Given this list of marker genes GM2A, DYNLT2B, WDPCP, GLUD1, TJP2, ZNF157, DENND3, SEL1L3, SPEN, XRN2, ZFYVE27, CLN3 (CLN3 lysosomal/endosomal transmembrane protein, battenin), SLC25A35, ELAC1, ARHGAP26, SLC15A4, P3H3, TERF2, RAB38, RPL38, RINT1, MACO1, BCO2 (beta-carotene oxygenase 2), EML6, ADAM22, TMEM191C, SRPK2, CCR6, SNAPC2, TMEM241, RCAN3, MAP3K2, DBF4, MAN2B1, RAMP1, CD4, BUB3, DUSP7, TMEM176B, PLEKHG3, SLC23A3, CD300C, CDK2AP1, HOXA7, THNSL1, ARL2BP, KMT2D, CDKL3, SLA, TMEM273, ZCCHC24 (zinc finger CCHC-type containing 24), ACSM3, AFMID, MCCC2, CD300LB, URI1, CD68, KRT16, KAZN (kazrin, periplakin interacting protein), CCNY, ACSS1, SGSH, GSN, MMGT1, ALKBH8, ZNF623, TSPAN9, DNAJB14, SLC9A9, CD74, FERMT3, CCDC28A, CYB5R1, SLC43A2, CEP162, CLEC4G, ZNF418, DCLRE1C, ACAD9, ALOX15, CSAD, BCKDHB, COL17A1, RASGRP3, CNR2, RUNDC1, AKAP11, AMPD3, CIPC, GBA1, NFATC1, KLRC2, TCTA, SHLD1, SLC29A3, PITHD1, HAGH, SETX, CARM1, TFAP4, HELB, NBDY, ILK, IFNGR1, APOE, FAM161A, DCP1B, IGLC7, FMNL3, TMEM175, RAC2, NAV1, CMYA5, ARHGAP9, C6orf136, VHL, PHF7, SZT2, TTC7A, MTCP1, DGKD, ESAM, FIBP, MSRB2, SERPINA1, SLC25A45, AP1M1, ABI3, PACS1, FAM13B, CYP7A1, NFYC, DHCR24, RAPH1, ZNF653, CARD10, FICD, TET2, SUPT5H (SPT5 homolog, DSIF elongation factor subunit), FLYWCH1, LIPA, LPXN, L1CAM, LINC00511, CSNK1E, SDCCAG8, PATJ, ZNF445, MYCBP2, B4GALT6, WDR3, INPP5K, UTRN (NCBI Gene Id 7402), CARD6, CD300LG, PDLIM2, FAM89B, TDO2, RACK1, POGLUT2, RTN1, SESN3, RAD23A, ACO1, BICRA, PLP2, RIPOR2, BTBD2, HLCS, MAPK7, STARD9, FERRY3, DOCK11, CEP295, EXOC6, ZSWIM3, VPS41, TPP1, NCEH1, NNT, SPAG9, PIERCE2, HLA-DRB1, TBC1D22A (TBC1 domain family member 22A), ZNF239, ATP23, DGLUCY, ZFP36L2, TMEM9B, VAMP1, FAM120B, REEP3, GCNT1, HRH1, ANTXR2 (NCBI Gene Id 118429), EML3, PTPRC, CELF4, AS3MT, NEK7, here is a description of the gene set: studied in species Homo sapiens Bcl6 germline deletion causes a prominent inflammatory disease, owing to over-expression of Th2 cytokines, and affects the properties of B cells prior to immunization. Therefore we established the B cell-specific Bcl6 deletion mice and analyze the gene expression of naive B cells under physiological conditions. Human Gene Set: GSE28737_FOLLICULAR_VS_MARGINAL_ZONE_BCELL_BCL6_HET_UP Genes up-regulated in heterozygous knockout of BCL6: follicular versus marginal zone source. from publication Kaji T, Ishige A, Hikida M, Taka J, Hijikata A, Kubo M, Nagashima T, Takahashi Y, Kurosaki T, Okada M, Ohara O, Rajewsky K, Takemori T (PMID 23027924)